Given this list of marker genes ING3, ZNF320, TMEM70, SLC26A4-AS1, SCX, RASSF6, IFT70A, ZNF568, TMEM191A, TMSB4X, AMY1B, IGFBP1, ALDH8A1, STAR, GOLGA6L7, CDK6, GGT2P, TAOK3, ICA1L, RAD51, RTL8B, QNG1, EXO5, FRMPD2B, ITM2B, DTNA, HBE1, ZNF93, CAMK2A, HECA, TMEM156, NME2, BMP8B, SIGLEC6, RPS6KA3, KCTD7, PCYOX1, HTR2A, SOD2-OT1, RFX4, ZNF160, HSP90AA2P, here is a description of the gene set: studied in species Homo sapiens Genes up-regulated in blood 7d vs 0hr in adults (18-45) after exposure to CN54gp140 adjuvanted with GLA-AF, time point 7D, administered i.m. from publication Anderson J, Olafsdottir TA, Kratochvil S, McKay PF, Östensson M, Persson J, Shattock RJ, Harandi AM (PMID 29535712) Systems biology approaches have recently provided new insights into the mechanisms of action of human vaccines and adjuvants. Here, we investigated early transcriptional signatures induced in whole blood of healthy subjects following vaccination with a recombinant HIV-1 envelope glycoprotein subunit CN54gp140 adjuvanted with the TLR4 agonist glucopyranosyl lipid adjuvant-aqueous formulation (GLA-AF) and correlated signatures to CN54gp140-specific serum antibody responses. Fourteen healthy volunteers aged 18-45 years were immunized intramuscularly three times at 1-month intervals and whole blood samples were collected at baseline, 6 h, and 1, 3, and 7 days post first immunization. Subtle changes in the transcriptomic profiles were observed following immunization, ranging from over 300 differentially expressed genes (DEGs) at day 1 to nearly 100 DEGs at day 7 following immunization. Functional pathway analysis revealed blood transcription modules (BTMs) related to general cell cycle activation, and innate immune cell activation at early time points, as well as BTMs related to T cells and B cell activation at the later time points post-immunization. Diverse CN54gp140-specific serum antibody responses of the subjects enabled their categorization into high or low responders, at early ( < 1 month) and late (up to 6 months) time points post vaccination. BTM analyses revealed repression of modules enriched in NK cells, and the mitochondrial electron chain, in individuals with high or sustained antigen-specific antibody responses. However, low responders showed an enhancement of BTMs associated with enrichment in myeloid cells and monocytes as well as integrin cell surface interactions. Flow cytometry analysis of peripheral blood mononuclear cells obtained from the subjects revealed an enhanced frequency of CD56<sup>dim</sup> NK cells in the majority of vaccines 14 days after vaccination as compared with the baseline. These results emphasize the utility of a systems biology approach to enhance our understanding on the mechanisms of action of TLR4 adjuvanted human vaccines. Human Gene Set: ANDERSON_BLOOD_CN54GP140_ADJUVANTED_WITH_GLA_AF_AGE_18_45YO_7DY_UP